The following is a description of a gene set: Human Gene Set: KEGG_MEDICUS_PATHOGEN_KSHV_VGPCR_TO_GNB_G_ERK_SIGNALING_PATHWAY Pathway Definition from KEGG: vGPCR -> GNB/G -> RAS -> RAF1 -> MEK -> ERK -> (HIF1A,FOS,JUN) => (VEGFA,PDGFB,ANGPT2) KSHV vGPCR to GNB/G-ERK signaling pathway. Pathway ID: N00157. Pathway type: Pathogen. Pathway class: nt06224 CXCR signaling. species: Homo sapiens, and this is the list of marker genes: MAPK1, HIF1A, GNG3, GNB4, GNB5, GNG2, FOS, RAF1, JUN, GNB3, GNG13, VEGFA, HRAS, GNGT2, PDGFB, MAPK3, KRAS, GNG5, MAP2K2 (NCBI Gene Id 85511), GNB1, GNB2, GNGT1, ANGPT2, GNG11, NRAS, GNG10, GNG12, GNG8, GNG7, GNG4, MAP2K1